The following is a description of a gene set: studied in species Homo sapiens Human Gene Set: REACTOME_RUNX3_REGULATES_WNT_SIGNALING RUNX3 regulates WNT signaling, and this is the list of marker genes: MYC, LEF1, TCF7, TCF7L1, CTNNB1, CCND1, RUNX3, TCF7L2